The following is a description of a gene set: part of: Negative regulation of MAPK pathway studied in species Homo sapiens Reactome Pathway: Negative feedback regulation of MAPK pathway MAPK pathway activation is limited by a number of negative feedback loops established by MAPK-dependent phosphorylations. Known substrates of activated MAPK proteins that lie upstream in the RAF/MAPK pathway include SOS, RAF1, BRAF, and MAP2K1, and this is the list of marker genes: MAPK3, MAP2K1, MAP2K2, MAPK1, BRAF, RAF1